Given this list of marker genes Cdh17, Il6, Irf8, Ada, Spi1, Il21, Phf14, Pou2af1, Itfg2, here is a description of the gene set: The process in which a B cell in the spleen acquires the specialized features of a germinal center B cell. Germinal center B cells are rapidly cycling B cells which have downregulated IgD expression and exhibit high levels of binding by peanut agglutinin (PNA). species: Mus musculus Mouse Gene Set: GOBP_GERMINAL_CENTER_B_CELL_DIFFERENTIATION